The following is a description of a gene set: studied in species Homo sapiens Optic atrophy Human Gene Set: HP_OPTIC_ATROPHY Atrophy of the optic nerve. Optic atrophy results from the death of the retinal ganglion cell axons that comprise the optic nerve and manifesting as a pale optic nerve on fundoscopy., and this is the list of marker genes: HMBS, PLK4, GLRX5, NALCN, EPG5, SNF8, PRKCZ, NTRK2, NRL, CDC42, ARL2BP, KCNC3, YAP1, MICOS13, MERTK, MKS1, PRDM16, TNFRSF11B, HUWE1, MPLKIP, CLP1, HIRA, SIL1, B9D2, FH, MRPS34, SYNE1, RBL2, WDR45, ADA2, ATIC, ANKH, GMPPB, PRICKLE3, CSF1R, EEF1A2, ARSA, CTNNA2, GJA1, EPRS1, MID2, FZR1, RHO, ATXN1, SEC23A, PEX1, SLC38A3, GABRB2, CA4, ACADS, ZNF408, SBF2, PRCD, BBS1, TBC1D24 (TBC1 domain family member 24), DIAPH1, DNMT1, ELP1, CTNNB1, TMEM237, SLC7A14, NMNAT1, NDUFAF5, MCOLN1, MT-ND3, DDB2, TUBGCP6, TBX1, IMPDH1 (inosine monophosphate dehydrogenase 1), ZFX, RNU7-1, PDXK, WNT3 (NCBI Gene Id 7473), SLC13A5, MGP, FGFR3, B3GALNT2, TSFM, ARL6, NARS2 (NCBI Gene Id 79731), ATRX, RPGRIP1L, IDH3A, MT-TW, CERKL, COL4A1, ATP1A2, MECR, NRCAM, RPIA, B4GAT1, PTCD3, FA2H, RP1, TRAPPC11, CBS, PEX13, FLVCR1, PDE6B, SCAPER, INTS11, BOLA3, CA2, MTO1, SNRNP200, TOE1, MT-TQ, TNFRSF11A, DPM2, ZNF592, PACS2, B3GLCT, MFSD8, NUP54, MMP23B, SPG7, MT-TN, GEMIN4, HSD17B10, PPT1, NDUFS2, TMEM63A, CHSY1, RXYLT1, SOX5, PMPCB, KRAS, MTHFR, PRUNE1, TGFB1, NADK2, VPS13B, VCAN, NDUFS1, CTC1 (NCBI Gene Id 80169), HIKESHI, ZPR1, REEP6, MFF, ATP6V1A, GPAA1, PDHX, SUMF1, IFT172, GABBR2, SLC1A2, TK2 (NCBI Gene Id 7084), TSC1, SEC24C, KCNC2, RAB3GAP1, VRK1, TXN2, DENND5A, PRPF6, MTSS2, IBA57, MAP2K2, CKAP2L, P4HTM, INTS8, ERCC4, PCARE, AP3B2, NDUFV2 (NADH:ubiquinone oxidoreductase core subunit V2), ARX, WFS1, TBC1D20, ERCC1 (ERCC excision repair 1, endonuclease non-catalytic subunit), EIF2B4, PDE6G, ZNF513, CASR, SH3TC2, SLC29A3, NIPBL, GABRG2, MPDU1, DOCK6, TULP1, DPM1, GRN (granulin precursor), LZTR1, LARGE1, TMEM126A, ERCC5, MAP2K1, RFC1, ATG7, GLB1, JMJD1C, PPP3CA, PEX11B, CRB1, PLA2G6, TMEM107, AKT3 (NCBI Gene Id 26068), AARS1, ELP4, UCHL1, SURF1, ERCC6, TMEM222, MT-CO2, MT-CO3, ALG8, NFIX, CTBP1, SNAP29, TCTN2, CDK19, RAB11B, VPS53, IMPG2, PDPN, RBP3, RRM2B, PRPH2, BRAF, CDHR1 (NCBI Gene Id 94000), ZNHIT3, HK1, SSBP1, MT-TF, CYFIP2, PPP1R21, SAG, ABCA4, PRPF3, IDH3B, NAGA, DARS2, WWOX, PEX2 (peroxisomal biogenesis factor 2), PANK2, POMGNT1, PEX12, SOST, FXN, DPAGT1, SON, ADAR, EYS, CSPP1, DPYSL5, CACNA1A, TBX4, AHR, CYP7B1, CRX, SH3BP2, PDSS1, KIZ, RDH12, MAG, CELF2, PNPLA6, SP7, NDUFA11, AGXT, POMT2, RLBP1, PEX6, RP2, YME1L1, RP1L1, TBCD, SLC25A19, TIMM8A (NCBI Gene Id 84782), DKC1, CNKSR2, ANTXR1, GABRA5, SEC31A, MT-TH, BCAP31, LRP4, COA8, CASK, IER3IP1, RPE65, ISCA2, STAMBP, MPDZ, SEMA4A, USH2A, MMUT, TMEM216, RECQL4, OSTM1, C19orf12, PAX6, MTFMT, MT-ND2, OFD1, ATAD3A, NELFA, NECAP1 (NCBI Gene Id 25977), YWHAG, ZEB2, MT-TK, KCNAB2, NFU1, RREB1, STT3B, CFAP410, POU3F4, ARHGEF18, MT-CYB, PLAA (NCBI Gene Id 9373), RERE, PCK1, NDUFAF2, GTPBP2, CYP27A1, SZT2, MICU1, DGUOK, ERCC3, ASXL1, GLA, ERCC8, FGFR2, CPLX1, ROM1, BTD, TRAPPC12, CCDC88A, IKBKG, PTPN22, NDUFAF4 (NCBI Gene Id 29078), PRPS1, CNGA1, SYNJ1, RBMX, POMT1, TRAK1 (NCBI Gene Id 22906), CISD2, RPGRIP1, MAK, DAG1, GRIN2D, MT-TL1, TCTN1, LUZP1, PIGU, KIF7, MMACHC, EXOSC5, AAAS, VPS35L, RHOA, THG1L, WASHC5, TACO1, NDUFA13, SKI, TWNK, COMT, RNF170, TUB, IFT140, GABRD, SYNGAP1, PRPF4, UBE3B, TFG, DHCR7, GALC, SLC44A1, KCTD7, POGZ, ATP5F1D, NOTCH2NLC, PEX26, HGSNAT, NUS1, ADAM22, MYO5A, WDR4, PI4KA, CLN3, TANGO2, KIAA1549, RAB18, TEFM, PROM1, XPC, POLR3A, FLRT1, DPYD, CEP290, ATXN7, DYRK1A, FOXRED1, PEX3, UBE4B, AGTPBP1, SCN8A, CNGB1, CACNA1B, TXNDC15, CASZ1, NBAS, ACOX1, ERF, KIF11, MT-TS2 (NCBI Gene Id 8020), PIEZO2 (piezo type mechanosensitive ion channel component 2), FAM161A, SLC39A14, SCYL2 (NCBI Gene Id 55681), NDP (NCBI Gene Id 4693), IFT88, TBCE, GNAQ, POLR3K (RNA polymerase III subunit K), DNM1, PEX16, KCNA2, TRAF7, MTPAP, WARS2, FKTN, SPATA7, DNM1L, ASPA, MT-ND1, PRPF8, CLRN1, GMPPA, CACNA2D1, EXOSC9, DNAJC19, TUBB4A, SDHA, PLP1, ST3GAL5, PLEKHM1, VPS11, SCYL1, ALG13, RAB23, VPS33A, TCTN3 (NCBI Gene Id 26123), LAMB1, CASP2 (NCBI Gene Id 835), TMEM67, UFD1, SELENOI, RAB3GAP2, SMOC1, ACO2, ATP1A3 (ATPase Na+/K+ transporting subunit alpha 3), MT-TV, MT-CO1, RSPO2, RP9, IMPG1, AMPD2, GUCA1B, KIF1A (kinesin family member 1A), ATP5F1A, FRMPD4, B9D1, TTC8, NEK2, TUBGCP2, L2HGDH, CLCN7, MT-ND4L, SV2A, FDX2, NT5C2, LETM1, BEST1, SARDH, NDUFA6, POMGNT2, OPA3, ALG3, EMC1, POLR1A, FKRP, AFF4, P4HA2, SLC6A9, TIMM50, PARS2, AP1S2, SRD5A3, PCYT2, NR2F1, AFG3L2, POMK, TBC1D7, GNA11, PORCN, FGF12, PEX5, RPS6KA3, DNAJC30, PRKAR1A, NUP62, PEX10, OPA1, EIF2B1, UBA5, MT-ND4, EXOSC3, HCN1, RNF216, ACTL6B, DNA2, RBM10, MCAT, PIGG, TWIST1, NSD2, TSEN54, KLHL7, PDE6A, SCN1A, HSPG2, CLTC, NDUFAF8, FBXO28, PEX19, MT-RNR1, SMCHD1, PIK3CA, SERAC1, CNNM4 (cyclin and CBS domain divalent metal cation transport mediator 4), IDS, CCDC22, DHDDS, POLG2, CRPPA, SLC52A2, GABRA2, PCLO (NCBI Gene Id 56630), SCN3A, MT-ATP8, CLCN3, TMTC3, POLG, BBS2, FCSK, ATP6V1B2, KAT6A, MT-TP, PIK3CD, KANSL1, BRAT1, TUBGCP4, ABHD12, CNOT3, NLRP3, FSCN2, EXOSC8, ERCC2, GJC2, TMEM231, MT-ATP6, EIF2B2 (eukaryotic translation initiation factor 2B subunit beta), ATP5F1E, TMEM53, HLA-B, LRAT, RGR, MT-ND5 (mitochondrially encoded NADH:ubiquinone oxidoreductase core subunit 5), PEX14, CPSF3, RPGR, TOPORS, ATP5MK, CFAP418, FOXG1, XPA, CHD7, HLA-DRB1, PSAP, NGLY1, TSC2, AGBL5, PRPF31, TCIRG1, MT-ND6, DHX38, AHI1, COG6, ARVCF, MTRFR, TNFSF11, LRP5, ATPAF2, WDR73, DALRD3, KNSTRN, ARL3, MFN2, KLC2, KCNB1, NR2E3, SNX10, TBC1D2B, SLC30A9, FBXL4, SLC19A2, MINPP1, FDXR, NEU1, GP1BB, CC2D2A, POLR3B, AUH, SPEN, MOGS (NCBI Gene Id 7841), SLC25A46, SEMA3E, MTOR